Given this list of marker genes Gm15089, Kdm5c, Gm6620, Ptchd1, Gm8534, Gm8346, Ubqln2, Klf8, Magea8, Samt4 (NCBI Gene Id 75185), Gpr143, Gm8569, Gm15102, Gm8366, Magea2, Actb-ps1, Gm15151, Ott, Apex2, Sat1, Gm15131, Samt2b, Gm15160, Gm15104, Gm6645, Kantr, Gm8606, Huwe1, Gm15159, Gm24460, Mir3620, Gm8402, Maged2, Acot9, Mir3113, Gm25895, Gm8577, Pfkfb1, 3010001F23Rik, Fgd1, Gm15095, Gm15148 (NCBI Gene Id 100039760), Gm45022, Magea1, Nbdy, Tsr2, Samt1b, Gm15143, Rragb, Gm15096, Gm15103, Gm5946, Gm4919, Gm22359, Gm15158, Iqsec2, Gm15093, Gm5060, Gm15267, Mir98 (microRNA 98), Cldn34b1, Smt3h1-ps, Cldn34a, Samt1c, Samt1, A230072E10Rik, Gm5645, Magea5, Gm15085, Spin2c, Gm5396, Gm15266 (predicted gene 15266), Itih6, Hsd17b10, Ribc1, Gm15090, Gm5646, Phf8, Tro, Luzp4, Gm5395, Samt2, Gm5947, Usp51, Gm650, Gm15091, Gm4997, Rps7-ps3, Gm22248, Fam120c, Gm15142, Smc1a, Gm15141, Gm7150, Shroom2, Amd-ps1, Gm16445, Cldn34b2, Rpl7a-ps12, Kctd12b, Gm8383, Gm7158, Magea6, Cypt3, Foxr2, 9530051G07Rik, Gm15101, Magea3, Mageh1, Wnk3, Alas2, Gm15097, Gm4750, Gm25429, Tspyl2, Vcf2, Gpr173, Samt1d (spermatogenesis associated multipass transmembrane protein 1d), Gm26441, 3110067C02Rik (NCBI Gene Id 73202), Gm15149, Gm15084, Rpl21-ps15, Gm15155, Gm6451, Gm8475, Prdx4, Mirlet7f-2, Rps12-ps7, Gm15132, Gm10439, Gm8595, Gm15087, Gm15147 (NCBI Gene Id 100504082), Gm15191, Gm24907, Gm15094, Gnl3l, Gm8424, Gm15105, here is a description of the gene set: Mouse Gene Set: chrXF3 species: Mus musculus